Given this list of marker genes Apex1, Xrcc1, here is a description of the gene set: Reactome Pathway: Resolution of AP sites via the single-nucleotide replacement pathway part of: Resolution of Abasic Sites (AP sites) electronically inferred by orthology from the curated human pathway This event has been computationally inferred from an event that has been demonstrated in another species.<p>The inference is based on the homology mapping from PANTHER. Briefly, reactions for which all involved PhysicalEntities (in input, output and catalyst) have a mapped orthologue/paralogue (for complexes at least 75% of components must have a mapping) are inferred to the other species. species: Mus musculus